Given this list of marker genes ACADL, HADH (hydroxyacyl-CoA dehydrogenase), CPT1A, ECHS1, LMF2, ACADSB, CPT2, NCAPH2, HADHA, CPT1B, ACAA2, NBN, ACAT1, ACSL1, ECI1, CRAT, ACADM, FHP2, ACADVL (NCBI Gene Id 37), DECR1, HSD17B10, HADHB, ACADS, AMACR, here is a description of the gene set: from publication Mootha VK, Lindgren CM, Eriksson KF, Subramanian A, Sihag S, Lehar J, Puigserver P, Carlsson E, Ridderstråle M, Laurila E, Houstis N, Daly MJ, Patterson N, Mesirov JP, Golub TR, Tamayo P, Spiegelman B, Lander ES, Hirschhorn JN, Altshuler D, Groop LC (PMID 12808457) DNA microarrays can be used to identify gene expression changes characteristic of human disease. This is challenging, however, when relevant differences are subtle at the level of individual genes. We introduce an analytical strategy, Gene Set Enrichment Analysis, designed to detect modest but coordinate changes in the expression of groups of functionally related genes. Using this approach, we identify a set of genes involved in oxidative phosphorylation whose expression is coordinately decreased in human diabetic muscle. Expression of these genes is high at sites of insulin-mediated glucose disposal, activated by PGC-1alpha and correlated with total-body aerobic capacity. Our results associate this gene set with clinically important variation in human metabolism and illustrate the value of pathway relationships in the analysis of genomic profiling experiments. species: Homo sapiens Human Gene Set: MOOTHA_FFA_OXYDATION Genes involved in free fatty acid oxidation; based on literature and sequence annotation resources and coverted to Affymetrix HG-U133A probe sets.